The following is a description of a gene set: species: Mus musculus The region of a virus, bacterial cell, mitochondrion or chloroplast to which the nucleic acid is confined. Mouse Gene Set: GOCC_NUCLEOID, and this is the list of marker genes: Dhx30, Prorp, Tfb1m, Polg2, Top1mt, Cps1, Mterf2, Vdac2, Atad3a, Uqcc2, Atp5f1b, Elac2, Sod2, Poldip2, Trmt10c, Tefm, Grsf1, Hadha, Dna2, Mterf1a, Hspa9, Mterf1b, Dbt, Ssbp1, Supv3l1, Polq, Shmt2, Tfam, Fastkd2, Clpx, Twnk, Polrmt, Slc25a5, Mthfs (NCBI Gene Id 75585), Hsd17b10, Tert, Lonp1, Vdac1, Polg, Tufm, Tfb2m, Lrrc59, Mpg (NCBI Gene Id 268395), Lrpprc, Ddx28, Fastkd5, Dnaja3, Mtnap1, Hadhb, Acadvl